The following is a description of a gene set: Mouse Gene Set: GOMF_OXIDOREDUCTASE_ACTIVITY_ACTING_ON_A_HEME_GROUP_OF_DONORS Catalysis of an oxidation-reduction (redox) reaction in which a heme group acts as a hydrogen or electron donor and reduces a hydrogen or electron acceptor. species: Mus musculus, and this is the list of marker genes: Surf1, Cox4i2 (cytochrome c oxidase subunit 4I2), Por, Cox7a1, mt-Co2, mt-Co3, Cox5a, mt-Co1 (mitochondrially encoded cytochrome c oxidase I), Cygb (cytoglobin)